The following is a description of a gene set: studied in species Mus musculus A phase of elevated metabolic activity, during which oxygen consumption increases made as part of a defense response; this leads to the production, by an NADH dependent system, of hydrogen peroxide (H2O2), superoxide anions and hydroxyl radicals. Mouse Gene Set: GOBP_RESPIRATORY_BURST_INVOLVED_IN_DEFENSE_RESPONSE, and this is the list of marker genes: Prdx2, Grn, Cybc1, Ins1, Slamf8, Ncf1, Mpo, Trem2, Dusp10, S100a9, Rps19, Lbp, Selenok, Lipa, Ins2